The following is a description of a gene set: species: Homo sapiens Regulation of IFNG signaling Human Gene Set: REACTOME_REGULATION_OF_IFNG_SIGNALING, and this is the list of marker genes: IFNG, PIAS1, IFNGR1, SOCS1, JAK2, SOCS3 (NCBI Gene Id 9021), PTPN1, PTPN11, PTPN6, PTPN2, STAT1, JAK1, IFNGR2, SUMO1